Given this list of marker genes ADRA1A, DAP, EMP1, PRF1, PEA15, RIPK1, BCL2L1, BCAP31, STAT1, BNIP3L, CD14, GADD45A, MAEA, CASP14, PSEN2, CD40, CD38, VDAC1, CGB3 (chorionic gonadotropin subunit beta 3), IL18, RRAGA, NFKBIA, LIMS1, TNFRSF21, EMP3, BIK, LYZ, GPR65, DAPK1, LY86, IL24, CD2, TNFAIP3, CXCR4, TNFRSF1B, TNFRSF25, LTBR, TUBB4B, TRAF1, CASP1, ADORA1, LGALS1, C6, DUSP6, GZMB, EIF2AK2, IL1B, TXNL1, CDK11A, AHR, FOSL2, GZMH, here is a description of the gene set: Human Gene Set: MODULE_399 species: Homo sapiens Genes in the cancer module 399.